The following is a description of a gene set: Human Gene Set: HP_ONION_BULB_FORMATION studied in species Homo sapiens Repeated episodes of segmental demyelination and remyelination lead to the accumulation of supernumerary Schwann cells around axons, which is referred to as onion bulb formation. This finding affects peripheral nerves. Onion bulb formation, and this is the list of marker genes: MPZ (myelin protein zero), PRX, SBF1, GDAP1, PMP2, PRPS1, SLC12A6, FIG4, DNM2, SBF2 (NCBI Gene Id 81846), PMP22, FGD4, HYCC1, GBF1, NEFL, YARS1, MFN2, MTRFR (NCBI Gene Id 91574), ARHGEF10, EGR2, SACS, NDRG1, LITAF, AFG3L2, KIF1B, INF2, COX6A1, DCAF8, LMNA, SH3TC2, GJB1, GNB4